Given this list of marker genes Dhx36, Ticam1, Stx4a, Rigi, Ptafr, Ighg1, Fcgr3, Ddx1 (DEAD box helicase 1), Itgb2l, Mavs, Tyrobp, Arg1, C3, Itgb2, Lypd10, F2rl1, Ighg2b, Fcgr1, Cd177, Stap1, Btk, Ddx21, Pomc, Itgam, Fcer1g, Cxcl1, Lypd11, H2-T23, Spi1, here is a description of the gene set: studied in species Mus musculus Mouse Gene Set: GOBP_POSITIVE_REGULATION_OF_MYELOID_LEUKOCYTE_MEDIATED_IMMUNITY Any process that activates or increases the frequency, rate, or extent of myeloid leukocyte mediated immunity.